Given this list of marker genes SDHA (NCBI Gene Id 6389), SDHB, SDHC, HTT, SDHD, here is a description of the gene set: Mutation-caused aberrant Htt to electron transfer in Complex II. Pathway ID: N00989. Pathway type: Variant. Pathway class: nt06461 Huntington disease. species: Homo sapiens Human Gene Set: KEGG_MEDICUS_VARIANT_MUTATION_CAUSED_ABERRANT_HTT_TO_ELECTRON_TRANSFER_IN_COMPLEX_II Pathway Definition from KEGG: HTT* -| CxII -> QH2